The following is a description of a gene set: Human Gene Set: GOBP_ECTODERMAL_CELL_DIFFERENTIATION studied in species Homo sapiens The process in which relatively unspecialized cells acquire specialized structural and/or functional features of an ectodermal cell. Differentiation includes the processes involved in commitment of a cell to a specific fate., and this is the list of marker genes: MIR145, VPS52, ITGA6, ETS2, FZD7, ELF5, ITGAM, EDA2R